Given this list of marker genes Etfbkmt, Hadha, Pah, Adtrp, Acoxl, Tigar, Adh1, Acadsb, Pfkm, Afmid, Oaz1, Npl (N-acetylneuraminate pyruvate lyase), Acad12, Mtln, Hmgcl, Ahcy, Aldh2, Rbks (NCBI Gene Id 71336), Akr1d1, Glb1l, Dao, Pgam2 (phosphoglycerate mutase 2), Acad10, Irs2, Hpd, Acat1, Akt1, Scarb1, Tdo2, Hk2, Pnkd, Ces1d, Pck2, Lep (NCBI Gene Id 16846), Dpep1, Dcxr, Hdc, Slc25a17, Akt2, Agxt, Acaa1b, Ppard, Hadh, Acaa1a, Ddah1, Kmo, Glb1l2, Slc27a4, Adal, Hsd17b6, Adhfe1, Mpi, Eno1, Cyp7a1, Acot4, Dera, Gnpda1, Abat, Aldh1b1, Oxct1, Gk5, Abhd1, Pdxp, Pipox, Cnr1, Eno1b, Arg2, Abcd3, Pycr3, Bcl2l13, Gldc, Acad8, Shmt1, Cpt2, Etfb, Uroc1, Cyp27a1, Nagk, Ido1, Nudt3, Nos2, Urah, Uox, Akr1a1, Got2, Mlycd, Upp1, Hal, Kynu, Amdhd1, Mgat1, Aldh6a1, Ntsr1, Gcdh, Acsbg2, Irs1, Cdadc1, Acad9, Ehhadh, Gpi1, Cyp1a1, Adh5, Mccc1, Nos1, Acaa2, Abcd4, Eno3, Sesn2, Cryl1, Miox, Hagh, Aasdhppt, Tdh, Sult2a8, Pck1, Cyp24a1, Aldh1l1, Nudt1, Lpin1, Acmsd, Dbi, Obp2a, Renbp (NCBI Gene Id 19703), Acadl, Lpin3, Bdh2, Prodh2, Galk1, Sult2a7, Bad, Cpt1b, Cyp4f18, Pten, Aldoa, Cyp4f13, Ido2, Dlat, Mfsd2a, Aldh1a7, Pon1, Gad2, Sult1e1, Ftcd, Actn3, Galt, Slc16a1, Synj2, Slc25a44, Ahcyl, Agxt2, Prodh, Thnsl2, Lonp2, Aldh3b1, Pfkfb2, Il4i1, Oxct2b, Bcat2, Acsf3, Abhd2, Entpd4, Pgk1, Gm1110, Cyp4f15, Apoe, Gk2, Decr1, Tha1, Abhd3, Adcy10, Adipoq, Cpt1a, Dlst, Src, Nqo2, Asrgl1, Cubn, Kyat3, Aldh3b2, Foxk1, Gpt, Trp53, Phyh, Lipe, Hibch, Eci2, Etfa, Cda, Pkm, Abcb11, Aldh5a1, Glb1, Sord, Ces1f, Gpt2, Qprt, Dhdh, Galm, Haao, Pon3, Lrp5, Upp2, Tkfc (triokinase, FMN cyclase), Urad, Scp2, Aldh1a1, Park7, Gcsh, Entpd4b (NCBI Gene Id 100862375), Gad1, Gapdh, Klf9, Sult2a5, Crot, Bckdha, Aldh4a1, Decr2, Hao1, Gatd1, Gpd2, Oat, Ppat, Pfkp, Sult1b1, Sult2a2, Etfdh, Bckdhb, Echdc2, Tpi1, Sdsl, Abcd1, Ech1, Acads, Plin5, Sult2a4, Crat, Arg1, Pnp, Cbs, Khk, Cyp26b1, Cyp26a1, Acacb, Echdc1, Hk1, Srd5a3, Hoga1, Aldh1l2, Eci3, Pgm1, Cyp4f14, Gcat (glycine C-acetyltransferase (2-amino-3-ketobutyrate-coenzyme A ligase)), Ldhd, Gls, Haghl, Adh4, Adh7, Strap, Ada, Bcat1, Eno2, Glud1, Gstz1, Fabp1, Slc27a2 (solute carrier family 27 (fatty acid transporter), member 2), Acox3, Dpep2, Esd, Ilvbl, Cyp26c1, Gda, Auh, Cdo1, Twist1, Pfkl, Fah, Nudt7, Acox1, Gk, Ldha, Nos3, Naalad2, Cyp4f40, Nudt5, Nudt19, Cyp39a1, Gale, Mtor (mechanistic target of rapamycin kinase), Ldhc, Qdpr, Dbt, Dctd, Dld, Hacl1, Xylb, Gnpda2, Mat1a, Mtrr, Mccc2 (NCBI Gene Id 78038), Glo1, Blmh, Acot8, Sult2a3, Aass, Hadhb, Fgf23, Lpin2, Pex13, Xdh, Atp2b4, Tysnd1, Aicda, Upb1, Cyp2w1, Pex7, Csad, Ppm1k, Cyp46a1, Acsl5, Sult2a6, Ivd, Enpp4, Pnp2 (NCBI Gene Id 667034), Kyat1, Abcd2, Aig1, Aldh8a1, Acad11, Glb1l3, Hgd, Eci1, Amt, Echs1, Nudt8, Sds, Pm20d2, Acot7, Hibadh, Hsd17b4, Aldob, Slc25a12, Hmgcll1, Acox2, Oxct2a, Mthfsl, Hsd3b7, Faah, Tat, Pex5, Cyp27b1, Dpyd, Pex2, Amdhd2, Hsd17b10, Gls2, Cbr3, Foxk2, Acadm, Got1, Glyctk, Sardh, Entpd7, Scly, Aadat, Akr1c18, Slc16a3, Sp1, Ddo, Gck, Otc, Acadvl, Sult2a1, Bckdk, here is a description of the gene set: Mouse Gene Set: GOBP_SMALL_MOLECULE_CATABOLIC_PROCESS species: Mus musculus The chemical reactions and pathways resulting in the breakdown of small molecules, any low molecular weight, monomeric, non-encoded molecule.